Given this list of marker genes Crbn, Sumo2, Trim63, Prickle1, Herc2, Rnf185, Cdc23, Klhl35, Akt1, Brinp1, Ankrd9, Plaa, Anapc16, Eif3h, Asb11, Aqp11, Plk2, Kbtbd6, Usp38, Cdc16, Filip1l, Rhbdd1, Siah3, Kbtbd3, Znrf1 (NCBI Gene Id 68110), Faf2, Wfs1, Psmd1 (NCBI Gene Id 70247), Mta1, Tdpoz5, Klhl17, Rchy1, Kcmf1, Ttc36, Cdc26, Tdpoz4, Edem1, Tbl1xr1, Pramel41, Rnf5, Ubxn11, Psma6 (proteasome subunit alpha 6), Ctnnb1, Ogt, Anapc4, Ube2v2 (ubiquitin-conjugating enzyme E2 variant 2), Cul5, Fbxl19, Trim38, Rbx1, Ufd1 (NCBI Gene Id 22230), Pramel22, Dnajc10, Otud5, Pja2, Akirin2, Psmb11, Skp1, Trib3, Gna12, Get4, Fbxo38, Rnf41, Nemf, Spopl, Atg7, Usp7, Rnf145, Pabpn1l, Pramel15, Sdf2l1, Apoe, Dcaf13 (NCBI Gene Id 223499), Trim28, Ubqln2, Cul4b, Oog3, Fbxw4, Pramel6, Map1a, Pramel24, Ube2g2, Ddit3, Zyg11b, Anapc5 (NCBI Gene Id 67965), Pramel25 (PRAME like 25), Paqr3, Kat5, Fbxo48, Vcp, Psme3ip1, Wwp2, Cdc20b, Anapc15-ps, Usp19, Psmb7, Tdpoz1, Ankzf1, Bfar, Trpc4ap, Ube2j1, Pramel13, Snhg15, Osbpl7, Ubxn1, Fbxw11, Rnf103, Pramel20, Park7, Pramel30, Psme2, Hamp, Dab2, Sel1l2, Zfand2a, Csnk2b, Erlec1, Midn, Styx-ps, Sirt6, Kcne2, Prkn, Erlin1, Tmub2, Glmn, Psmd6, Ecpas, Fbxl17, Gm13040, Fem1b, Stub1, Fem1al, Fbxl6, Klhl41, Senp1, Desi1, Cdc34b, Foxf2, Arrb1, Dda1, Anapc2, Sumo1, Tdpoz8, Psmb8, Ecrg4, Klhl10, Ube2h, Socs2, Cav1, Fbxl13, Kbtbd12, Ubb, Tmem129, Trip12, Psen1 (presenilin 1), Smarcc1, Gsk3a, Psma4 (proteasome subunit alpha 4), Hspa5, Ubr1, Ube2j2, Nhlrc1, Skp2, Pramel19, Keap1, Fbxl3, Ern1, Edem3, Siah1b, Zer1, Klhl20, Alad, Ube2srt, Bcap31, Zfand2b, Calr, Ecscr, Ipp, Nupr1, Ube2w (NCBI Gene Id 66799), Ddrgk1, Pramel38, Psmd2, Fzr1, Sh3bgrl, Spopfm2, Spop, Hectd3, Fbxw7, Ubr2, Dab2ip, Fbxo17, Cul1, Dnaaf4, Trim39, Csnk2a2, Usp9x, Tor1a, Tmub1, E330034G19Rik, Ppp2r5c, Psmb6, Spopfm3, Rnf186, Fbxo6 (NCBI Gene Id 99978), Foxred2, Pramel1, Pramel11, Eif2ak3, Pml, Nccrp1, Pramel29, Hfe, Rnft1, Anapc10, Rnf139, Psma5, Marchf6, Rnf122, Gba1, Ophn1, Rnf4, Ubxn6, Trim25, Ubxn2a, Klhl2, Bag6, Socs6, Fbxl20, Ccar2, Pcbp2, Trem2, Psme4, Pramel31, Dtx4, Spsb3, Klhl18, Hsp90ab1, Syvn1, Ddb1, Kctd5, Plk3, Trim45, Pramel32, Klhdc10, Marchf7, F8a, Gan, Pramel12, Clec16a, Psmb5, Kbtbd7, Clgn, Rmnd5a, Siah2 (siah E3 ubiquitin protein ligase 2), Ppp2cb, Wwtr1, Naglu, Klhl1, Rnf7, N4bp1, Pramel33, Ascc3, Ambra1, Fbxl2, Fbxl7, Axin2, Cdc20, Trim71, Ubqln1, Oog2, Sgta, Pmp22, Sec61bl, Ate1, Rnf34, Klhl21, Tmtc3, Pramel36, Stt3b, Psmb4, Lrrc75a, Man1b1, Zfp418, Ddi1, Anapc11, Aurka, Zswim8, Sel1l, Jkamp, Rybp, Brsk2, Fbxo39, Sirt2, Ube4a, Cul2, Psen2, Man1c1, Pramel23, Ascc2, Cop1, Erlin2, Pramel26, Apc, Tmf1, Pabir1, Siah1a, Ivns1abp, Ube4b, Rnf216, Gabarapl2, Ccdc47, Klhl42, Smurf1, Sh3rf3, Traf4 (TNF receptor associated factor 4), Derl1, Ccnf, Nrros, Canx, Trim72, Klhl30, Rnf10, Klhl15, Fbxl18, Pramel40, Klhl28, Rnf40, Psmd8 (proteasome (prosome, macropain) 26S subunit, non-ATPase, 8), Oog4, Umod, Pramel5, Gpx1, Aup1, Usp13, Pias1, Fhit, Uchl5, Klhl7, Pramel46, Lamp3, Kctd13, Caml (NCBI Gene Id 12328), Cbfa2t3, Pramel44, Klhl29, Yod1, Arrb2, Spsb2, Ube2s, Trim26, Pramel42, Rnf121, Ubr5, Pkd1, Wnt10b, Tmx1, Kif14, Dtl, Fbxo31, Psmc5, Psme3, Clock, Nhlrc3 (NHL repeat containing 3), Spsb4, Hspa1b, Sco1, Ubr4, Klhl6 (kelch-like 6), Ube2b, Fbxo11, Csnk1a1, Psmd10, Fbxw5, Appbp2, Rffl, Nedd4l, Psme1, Pramel53, Psma7, Kbtbd8, Ube2n, Zfp598, Nfe2l1, Ube2u, Dcaf1, Csnk1d, Nudt15, Ube2d1, Pramel35, Apc2, Oog1, Prpf19, Psmc2, Edem2, Commd1, Fbxo44 (F-box protein 44), Fbxl16, Fbxo9, Rybp-ps, Herpud1, Il33, Agap3, Ubac2, Fbxl9 (NCBI Gene Id 234684), Dnajb12, Xbp1, Gipc1, Oaz1, Pramel16, Rbck1, Rhbdf1, Trib1, Pramel47, Pramel48, Trim2, Peli1, Fbxl22, Trf, Fem1c, Kbtbd2, Eif2a, Afg2b, Klhdc2 (kelch domain containing 2), Nploc4, Trim13, Rack1, Selenos, Fbxo7, Hsp90b1, Bag2, Pramel18, Vhl, Fbxo2, Rnf170, Psmd4, Socs5 (suppressor of cytokine signaling 5), Btrc, Dlgap1, Fem1a, Cdc27, Psmd7, Sh3rf2, Tdpoz2, Ercc8, Ube2d3, Faf1, Prkaca, Znrf4, Rnft2, Gid8, Wwp1, Psmb9 (proteasome (prosome, macropain) subunit, beta type 9 (large multifunctional peptidase 2)), Klhl23, Psmc6, Rpl11, Amn1, Socs4, Pmaip1, Bmal1, Bag5, Huwe1, Ift80, Psmf1, Nsfl1c, Ddi2, Dnajb9, Birc2, Rnf126, Asb2, Derl2, Usp44, Klhdc3, Derl3, Trip4, Clu (clusterin), Usp26, Dcaf12, Anapc13, Klhl3, Hectd1, Psmd14, Arih2, Hspbp1, Ube2k, Rcn3, Armc8, Gsk3b, Svip, Trib2, Rad23b (NCBI Gene Id 78352), Sirt1 (NCBI Gene Id 93759), Araf, Psmb2, Trim9, Fbxo45, Atxn3, Spsb1, Gabarap, Pramel17 (NCBI Gene Id 545662), Kctd10, Anapc1, Pramel28, Sec61b, Tbl1x, Smurf2, Anapc7, Pramex1, Usp5, Ube3a (ubiquitin protein ligase E3A), Ankrd11, Ubxn8, Dvl1, Gclc (NCBI Gene Id 28039), Asb1, Anapc15, Kctd2, Ufl1, Amfr, Bbs7, Dcaf11, Nop53, Tbx21, Klhl11, Psmc1, Man1a, Ccin, Znrf2, Fbxl4, Usp14, Ube3d, Prkcg, Tnfaip1, Pramel37 (NCBI Gene Id 381724), Ubxn10, Phf20l1, Psma1, Mtm1, Ltn1, Xpo1, Klhl5, Cul3 (NCBI Gene Id 98674), Tmem259, Klhl12 (NCBI Gene Id 240756), Lrrk2, Taf9, Fbxo3, Ube2g1, Klhl24, Fbxl5, Fbxw8, Styx, Cdc34, Tmem67, Dnajb2, Mapk8, Tdpoz9, Rnf180, Tdpoz3, Pramel27, Rhobtb3, Itch, Trim3 (NCBI Gene Id 55992), Calr3, Psmc3, Ube2a, Gid4, Ubxn2b, Mapk9, Klhl38, Nkd2, Pramel21, Cd2ap, Dmac2 (distal membrane arm assembly complex 2), Asb9, Trim21, Chfr, Mdm2, Klhdc1, Sharpin, Psmb10, Epm2a, Klhl22 (NCBI Gene Id 72509), Sh3rf1 (SH3 domain containing ring finger 1), Usp25, Topors, Pramel7, Ubr3, Psma3, Psma2, Pramel43, Shh, Pithd1, Pramel55, Rbx1-ps, Fbxo27, Ube2c, Rmnd5b, Fbxl15, Klhl40, Ubxn7, Det1, Nr1d1, Psmc4, Rnf187, H13, Nub1, Os9, Plk1, Calr4, Klhl8, Nfe2l2, Pramel60, Cul4a, Kctd17, Hspa1a, Fbxl14, Rad23a, Pbk, Wdr26, Maea (NCBI Gene Id 80495), Klhl4, Pcnp, Fbxo4, Pramel14, Csnk1e, Pramel51, Ubxn4, Fbxo22, Psmb3, Enc1, Man1a2, Pramel45, Tlk2, Fmr1, Axin1, Psma8, Ubqln4, Socs7, Wac (NCBI Gene Id 76331), here is a description of the gene set: studied in species Mus musculus The chemical reactions and pathways resulting in the breakdown of a protein or peptide by hydrolysis of its peptide bonds that is mediated by the proteasome. Mouse Gene Set: GOBP_PROTEASOMAL_PROTEIN_CATABOLIC_PROCESS